Given this list of marker genes 9330020H09Rik, Ankrd33, Gm4468 (NCBI Gene Id 108168266), Gm25897, Letmd1, Larp4, Or10ad1, Slc48a1, Atf1, B130046B21Rik, Kansl2, Or10ad1c, Or5bs2, Slc4a8, Tmem106c, Senp1, Gm33666, Gm25999, Gm41396, Scn8a, Gm34939, Tamalin, Scaf11, Slc38a2 (solute carrier family 38, member 2), Ccdc184, Methig1, Faim2, Gm18095, Gm16537, Tuba1c, Slc38a4, Nckap5los, Gpd1, Aqp2, Prpf40b, C1ql4, Tmbim6, Asic1, Or11m3, 1700031M16Rik, Vdr, AU021063, Rapgef3, Acvr1b, Zfp641, Gm25668, Tfcp2, Col2a1, Dhh, Nckap5l, Gm21917, 5330439K02Rik, Wnt1, Slc11a2, Cox14, 4930478M13Rik (NCBI Gene Id 74984), Rapgef3os2, Gm5475, Gm17057, Tmt1a2, Uqcrh-ps1, Higd1c, Tmt1a, Acvrl1, Gm20564, Slc38a1, Hdac7, Fam186b, Snora2b, Gm8888, Prkag1, Prph, 5730414N17Rik (RIKEN cDNA 5730414N17 gene), Atg101, Kcnh3, Ddn, Kmt2d, Or10ad1b, H1f7, Adcy6, Gm41392, Gm5808, Cela1, Gm8973 (predicted gene 8973), Gm34284, Or8s10, Arid2, Bin2, Rhebl1, Fignl2 (fidgetin-like 2), Ccdc65, Or8s2, Tmprss12, Cers5, Fmnl3, Mir1291, Arf3, Pou6f1, 4930578M01Rik, Mir6961, Gm4383, Olfr278-ps1, Pced1b, Rpl10a-ps3, Cacnb3, Racgap1, Ddx23, Or8s8, Ccnt1, Mir6962, Gm22045, Troap, C330013E15Rik, Gm35569, Pfkm, Lalba, Csrnp2, Lima1, Asb8, Bcdin3d, Dip2b, Fam186a, Tmdd1, Endou, Fkbp11, Smagp, Galnt6, Or8s16, Galnt6os, Gm18890, 1700120C14Rik, Gm26513, Spats2, A330009N23Rik, Or8s5, Tuba1b, Tuba1a (tubulin, alpha 1A), Spmip11, Gm17546, Smim41, Nr4a1, Smarcd1 (NCBI Gene Id 83797), D030018L15Rik (NCBI Gene Id 402773), Rnd1, Gm32885, 2310068J16Rik, Gm25183, Aqp6, Gm34152, Rpap3, Dnajc22, Mcrs1, I730030J21Rik, Lmbr1l, 2610037D02Rik, Tmt1a3, Gm17241, Dazap2, Amigo2, Mir6960, Gm6979, Aqp5, Wnt10b, here is a description of the gene set: species: Mus musculus Mouse Gene Set: chr15F1